Given this list of marker genes ZNF80, CERT1, FUNDC2, PURB (purine rich element binding protein B), MOAP1, PMPCB, VPS13C, XPR1, CENPN, MCMDC2, MAN1A2, DICER1, GALNTL6, EYS, CC2D1B, KLF17, STOML3 (stomatin like 3), DDX3X, PRKD1, NRXN1, POLR1F, ANKS1B, SLC44A1, KCNK13, ACVR1C, FKBP5, UBE3A, TLL1, ANO3, SCAMP1, NTN4, SLC43A3, SGCZ (sarcoglycan zeta), NENF, FGF13, HMGN4, FOXF1, SAA2, TRPM3, FLRT3, CEP19, RASA2, PRELID3B, MBNL1, PACSIN1, PLPBP, TNIK, TMEM254, RBMS3, CREB1, CDKN2C, LCORL, AGO1, ELOVL7 (ELOVL fatty acid elongase 7), SNX9, FBXO33, LDAH, CLEC2B, ZNF704, ELOVL6, CNTNAP2, SPART, RAB6A, NEDD9, TUFT1, NDUFA5, TNPO1, CFL2 (cofilin 2), CGNL1, PAK3, CNOT7, ZFYVE28, AJAP1 (adherens junctions associated protein 1), DMRTA1, PHYHIPL, PREPL, CCN2, ELAVL4, USP49, MSRB3, ARRDC3, PDGFD, RANBP17, RCSD1, BCL11A, SEC61A2, PPP1R15B, LAMP2, AFF2, TENM1, HNRNPR, BACH1, PEAK1, MOK, C5orf24, RNASEL, TNRC6C, EIF4G3, MMD (NCBI Gene Id 23531), RORA, PITPNC1, SNIP1, HMGA2, PAQR5, RYBP, FNIP2, HCN1, RHPN2, RFX3, ATMIN, MAEA, CBL (Cbl proto-oncogene), CCDC91, ATF6, PROS1, SLC16A6, EXOSC8, SEMA5A, FBN1, LZTFL1, CAPZB, PCDHA9, SERPINE2, SLC25A26, CBX5, SINHCAF, SOSTDC1, ENPP6, VWC2, RFXAP, TMEM68, CREBRF, FBXO11, CARF, XKR6, IGSF5, TPSB2, MLIP, FZD7, MED21, AFG1L (NCBI Gene Id 246269), LRRTM3, TMTC1, PIK3R1, FOXN2, KLHL15, ITPRIPL2, SH2D1B, YAF2, FZD3, LHX8, MPZL3, RAD51AP2, ZC2HC1B, IGF2R, APOBEC4, PLCXD3, EDNRB, TNFSF13B, STXBP5L, ITGA1, TCIM, PAPOLA, ARHGAP6, ZNF25, ARHGEF38, TMED4, BACH2, MTA3, CSNK1G3, TM6SF1, PAX3, MOSMO, USP8, SCLT1, UBE3C, LRRTM2, OR2L13, CYP4V2, ERF, C21orf91, SWAP70, PRKAB1, DENND1B, SYNJ1, RASGEF1B, ONECUT2, SP110, SPRED2, SLC39A9, YBX2, COA8, KATNBL1, DNAJB14, GDF6, PLXDC2, TUSC3, CHEK1, SGIP1, NEK7 (NIMA related kinase 7), CENPQ, ZNF646, PBX3, ZNF100, STARD7, RALGPS2, CXCL9, ACKR4 (NCBI Gene Id 51554), ISM1, PPARGC1A, HYDIN, RSPO3, FYTTD1, AAK1, MBD2, ZBTB2, COL8A1, P2RY14 (purinergic receptor P2Y14), DNAJC21, AKNAD1, ARL6IP6, PHACTR1, SMIM10L1, SETD6, BEST3, QKI, ZNF570, GNL3L, NFIA, PLCB4, ESD, MBLAC2, BRIP1, PUM2, CSRNP2, BBX, SERTM1 (serine rich and transmembrane domain containing 1), SOCS4, CDC27, LEPROT, C7, SMYD3, here is a description of the gene set: Human Gene Set: MIR2052 from publication Chen Y, Wang X (PMID 31504780) Genes predicted to be targets of miRBase v22 microRNA hsa-miR-2052 in miRDB v6.0 with MirTarget v4 prediction scores > 80 (high confidence targets). studied in species Homo sapiens